Given this list of marker genes NACAD, SAR1B, GAS2, LRRC61, NANS, CD200, RNH1, CCDC184 (coiled-coil domain containing 184), ST13, MTRES1, FAM234A, CSTB, NCALD (neurocalcin delta), FUCA1, CFAP36, AKNAD1, SLC12A4, CHCHD5, SLC9B2, HINT3, CCT4, LARGE2, NMRAL1, DGCR6, MORN2, IFI27L2 (NCBI Gene Id 83982), SLC44A1, GALC, EMD, CEBPZOS, RASAL1, DDT, HSPA1B, TRPM4, PPFIBP1, ANAPC13, BAX, VCL, DCAF4, EHD1, ZBTB32, TUBB, PSRC1, NINJ2, SH3GLB1, DSTN, ACTC1, MRPS16, KIAA1958, RCN1, STIL, PPP2R3A, RFC4, HLA-DMA, ELOC, PLEK, BNIPL, C8orf76, ELL2, PYCARD (NCBI Gene Id 29108), CISD1, TFF1 (trefoil factor 1), TM7SF2, PTPN13, EEA1, CRTAM, MRPL58, DUSP11, ATP5MC2, CYSTM1, AGPAT4, EGR2, LRG1, HMOX2, SLC25A6, NRN1 (neuritin 1), CCN6, SLIRP, PRIM2, CD70, LRFN1, INSL6 (insulin like 6), NDFIP2, CFAP68, ACTL7A, MVK, KLHDC7A, ICAM4, UBE2A, HNRNPA1, TMBIM1, BAIAP2, SPC24, FHL2, FYTTD1, PSAT1, E2F8, P3H1, MAN1A1, CCL5, TMEM14A, NCBP2AS2, MYB, TMEM126A, CUX1, SMARCA5, MRPL32, NEK6, FAM229B, PLP2, CRELD1, TNFSF13B, FAS, NKIRAS2, MPZL2, NDUFC2, GLUD1, LSM11, FUBP3, NENF, MCRIP2 (MAPK regulated corepressor interacting protein 2), PRXL2A, ZNF296, CFD, DUOXA1 (NCBI Gene Id 90527), PDK3, CAMK2D, RPL31, PIN4, MRPL4, PHLDA3, ANAPC15, BLOC1S2, ARL3, PALS2, SMPDL3B, CFAP119, HGF, NT5C3A, H2BC5, EPHX1, SCN4B, TMEM242, NDUFS2, EEF1G, AP2S1, ERGIC1, CENPH, NPAS4, BIN3, FBXW9, TNFSF14, VASH1, CNIH2, SSR3, TMEM120A, WDR19, CD320, EIF2S3, CEP83, MZT2B, MDM2, LIG1, SYN1, GLB1, PSMD8, HINT1, ITIH5, CCT5, VASH2, NUBP1, EIF2S2, LAG3, TIMM17B, PRCP, FARS2, RBMS2, CAV2, CLDN7, POLD4, GNB5, POC1A, WSB2, UQCRC2, CA13, INKA1, TUBB6, LAMTOR4, CFAP20, IQGAP3, IFT43, ATP5F1E, DHX58, AP4M1, SKA1, RP9, ROPN1L, GGH, THG1L, MMGT1, here is a description of the gene set: from publication Ouyang W, Liao W, Luo CT, Yin N, Huse M, Kim MV, Peng M, Chan P, Ma Q, Mo Y, Meijer D, Zhao K, Rudensky AY, Atwal G, Zhang MQ, Li MO (PMID 23135404) studied in species Homo sapiens Genes down-regulated in normal T reg (nTreg): FOXO1 versus wildtype. Regulatory T (Treg) cells characterized by expression of the transcription factor forkhead box P3 (Foxp3) maintain immune homeostasis by suppressing self-destructive immune responses1-4. Foxp3 operates as a late acting differentiation factor controlling Treg cell homeostasis and function5, whereas the early Treg cell lineage commitment is regulated by the Akt kinase and the forkhead box O (Foxo) family of transcription factors6-10. However, whether Foxo proteins act beyond the Treg cell commitment stage to control Treg cell homeostasis and function remains largely unexplored. Here we show that Foxo1 is a pivotal regulator of Treg cell function. Treg cells express high amounts of Foxo1, and display reduced T-cell receptor-induced Akt activation, Foxo1 phosphorylation, and Foxo1 nuclear exclusion. Mice with Treg cell-specific deletion of Foxo1 develop a fatal inflammatory disorder similar in severity to Foxp3-deficient mice, but without the loss of Treg cells. Genome-wide analysis of Foxo1 binding sites reveals ~300 Foxo1-bound target genes, including the proinflammatory cytokine Ifng, that do not appear to be directly regulated by Foxp3. These findings demonstrate that the evolutionarily ancient Akt-Foxo1 signaling module controls a novel genetic program indispensable for Treg cell function. Human Gene Set: GSE40655_FOXO1_KO_VS_WT_NTREG_DN